Given this list of marker genes JARID2, ADCY9, MICB, BCL7A, RRP1B, FOXO1, ATP2B1, SSBP2, TUT4, ZNF638, MN1, ZNF451, ADGRL2, TOP2A, CUL1, INSIG2, TLK2, ATP13A3, USP24, CDYL, TLK1, DIO1 (NCBI Gene Id 1733), KAT6A, SPOP, DOCK4, RBPJ, TOGARAM1, CCNB2, FNBP1L, IGF2BP3, CNOT4, PMS1, WAPL, SMC4, FRYL, QKI, USP6, CREB3L2, KAT6B (NCBI Gene Id 23522), AJAP1, ABL1, KIF23, BUB1B, POLD3, E2F5, XPA, CTBP2, RABGAP1L, PIP4K2B, SLBP, MEGF9, CENPC, LSM14A, VLDLR, CENPA, CHD9, CLASP1, RNF13, CNOT2, PPP1R12A, CASP8, STRN, PHF3, ATF2, NAV3, ARHGEF7, MTCL1, MTUS1, MKI67, PHIP, LPCAT1, WWC1 (NCBI Gene Id 23286), NFKB1, ORC2, MLH3, FAT1, LARP7, PTK2, TP63, XPO1, FOXO3, UBL3, RRS1, NAA20, ZNF146, MEIS1, FERMT2, HMGA2, AUTS2 (activator of transcription and developmental regulator AUTS2), VEGFC, DOP1A, IRS1, UBR5, ADSL, SMC5, ZZZ3, SLC25A36, PUDP, MAST4, FAT2, VPS13B, KLF7, PALM2AKAP2, PIK3C3, MARCHF6, KLHL9, ZMYND8, CEBPD, SLC9A6, EXPH5, EDRF1, TLE4, BBX (NCBI Gene Id 56987), APPBP2, FNDC3A (NCBI Gene Id 22862), GNE, MECP2, FYN, SMAD3, NPAS2, BAZ1A, SHOC2, BIRC2, ZHX2, MBD2, OTUD4, POLE2, PHLPP1, KIF14, AGO2, ZMIZ1, SLC7A1, CCNB1, DOCK9 (NCBI Gene Id 23348), KIF11, SUCO, PAFAH1B1, MICAL2, TUBGCP3, REV3L, FGFR2, MAP3K5, KIF2A, PIKFYVE, SP3, here is a description of the gene set: from publication Dazard JE, Gal H, Amariglio N, Rechavi G, Domany E, Givol D (PMID 12771951) To gain insight into the transformation of epidermal cells into squamous carcinoma cells (SCC), we compared the response to ultraviolet B radiation (UVB) of normal human epidermal keratinocytes (NHEK) versus their transformed counterpart, SCC, using biological and molecular profiling. DNA microarray analyses (Affymetrix), approximately genes) indicated that the major group of upregulated genes in keratinocytes fall into three categories: (i). antiapoptotic and cell survival factors, including chemokines of the CXC/CC subfamilies (e.g. IL-8, GRO-1, -2, -3, SCYA20), growth factors (e.g. HB-EGF, CTGF, INSL-4), and proinflammatory mediators (e.g. COX-2, S100A9), (ii). DNA repair-related genes (e.g. GADD45, ERCC, BTG-1, Histones), and (iii). ECM proteases (MMP-1, -10). The major downregulated genes are DeltaNp63 and PUMILIO, two potential markers for the maintenance of keratinocyte stem cells. NHEK were found to be more resistant than SCC to UVB-induced apoptosis and this resistance was mainly because of the protection from cell death by secreted survival factors, since it can be transferred from NHEK to SCC cultures by the conditioned medium. Whereas the response of keratinocytes to UVB involved regulation of key checkpoint genes (p53, MDM2, p21(Cip1), DeltaNp63), as well as antiapoptotic and DNA repair-related genes - no or little regulation of these genes was observed in SCC. The effect of UVB on NHEK and SCC resulted in upregulation of 251 and genes, respectively, and downregulation of genes in NHEK and genes in SCC. To further analyse these changes, we used a novel unsupervised coupled two-way clustering method that allowed the identification of groups of genes that clearly partitioned keratinocytes from SCC, including a group of genes whose constitutive expression levels were similar before UVB. This allowed the identification of discriminating genes not otherwise revealed by simple static comparison in the absence of UVB irradiation. The implication of the changes in gene profile in keratinocytes for epithelial cancer is discussed. Cluster G6: genes increasingly down-regulated in NHEK cells (normal keratinocyte) after UV-B irradiation. studied in species Homo sapiens Human Gene Set: DAZARD_UV_RESPONSE_CLUSTER_G6